Given this list of marker genes HLX, ZBTB7B, STAT5A, LOXL3, SMAD7, ZC3H12A, RC3H2, ASCL2, FOXP3, CD69, SOCS5, TNFSF4, IL4R, BCL6, IL2, RC3H1, ANXA1, LGALS1, JAK3, TBX21, TNFSF18, here is a description of the gene set: Human Gene Set: GOBP_NEGATIVE_REGULATION_OF_T_HELPER_CELL_DIFFERENTIATION Any process that stops, prevents, or reduces the frequency, rate or extent of T-helper cell differentiation. studied in species Homo sapiens